The following is a description of a gene set: NR1H2 and NR1H3-mediated signaling studied in species Mus musculus Mouse Gene Set: REACTOME_NR1H2_AND_NR1H3_MEDIATED_SIGNALING, and this is the list of marker genes: Rxrb, Ncor2, Gps2, Tbl1x, Abca1, Nr1h2, Nr1h3, Ncoa1, Rxra, Tbl1xr1, Hdac3, Ep300